The following is a description of a gene set: Human Gene Set: GOCC_TRIGLYCERIDE_RICH_PLASMA_LIPOPROTEIN_PARTICLE A plasma lipoprotein particle that has a hydrophobic core enriched in triglycerides surrounded by an amphipathic monolayer of phospholipids, cholesterol and apolipoproteins. Triglyceride-rich lipoprotein particles transport lipids, which are non-covalently associated with the particles, in the blood. studied in species Homo sapiens, and this is the list of marker genes: APOB, APP, APOC4, APOM, APOBR, APOO, PCYOX1, APOE, APOA4, SELENOS, APOA2, APOC2, APOC3, VLDLR, LSR, LPL, APOA5, APOH, APOC1, APOA1, APOL1